Given this list of marker genes DEPDC5, SLC38A9, RRAGC, SESN1, ATP6V1G2, FNIP1, KICS2, WDR24, FLCN, SAMTOR, MIOS, RRAGA, ITFG2 (integrin alpha FG-GAP repeat containing 2), ATP6V1E1, RPTOR, CASTOR2, LAMTOR5 (late endosomal/lysosomal adaptor, MAPK and MTOR activator 5), ATP6V1F (ATPase H+ transporting V1 subunit F), ATP6V1C2, SEC13, SH3BP4, ATP6V0E2, NPRL3, ATP6V1D, LAMTOR2, RHEB, ATP6V1C1, NPRL2, ATP6V1B1, KPTN, SEH1L, ATP6V1H, RRAGB, ATP6V1G1, ATP6V1A, LAMTOR3, ATP6V0B, ATP6V1B2, ATP6V1E2, TCIRG1, ATP6V0E1, ATP6V0D1, ATP6V1G3, ATP6V0D2, SESN2, SZT2, RRAGD, ATP6V0C, LAMTOR4, WDR59, FNIP2, LAMTOR1, MTOR, MLST8, CASTOR1, here is a description of the gene set: species: Homo sapiens Amino acids regulate mTORC1 Human Gene Set: REACTOME_AMINO_ACIDS_REGULATE_MTORC1